Given this list of marker genes IL1R1, CD99, ADAM8, CD99L2, XG, RIPOR2, MDK (midkine), FUT7, here is a description of the gene set: studied in species Homo sapiens Any process that modulates the frequency, rate or extent of neutrophil extravasation. Human Gene Set: GOBP_REGULATION_OF_NEUTROPHIL_EXTRAVASATION